Given this list of marker genes MIRLET7E, MIRLET7F2, MIRLET7A2, MIRLET7I, MIRLET7G, MIRLET7C, MYC, KLF4, MIRLET7A1, POU5F1, EGR1, TRIM71, MIRLET7F1, MIRLET7D, SOX2, here is a description of the gene set: Human Gene Set: WP_LET7_INHIBITION_OF_ES_CELL_REPROGRAMMING let-7 inhibition of ES cell reprogramming species: Homo sapiens